Given this list of marker genes RNA5SP75 (RNA, 5S ribosomal pseudogene 75), RNA5SP19, RNA5SP490, RNA5SP37, RNA5SP22, RNA5SP151, RNA5SP106, RNA5SP280, RNA5SP166, NDUFS7, RNA5SP319, RNA5SP515, PEX3, RNA5SP387, REEP2, RNA5SP368, RNA5SP452, RNA5SP41, MT-RNR1, RNA5SP152 (RNA, 5S ribosomal pseudogene 152), DHX58, RNA5SP53, RNA5SP206, PLEKHG2, RNA5SP195, RNA5SP308, RNA5SP481, RNA5SP218, RNA5SP362, GYS1, RASGRP3, LTBP4, RNA5SP124, FAM230G, MTCO3P12, RNA5SP304, RNA5SP252, RNA5SP221, SYNE1, RNA5SP431, RNA5SP332, RNA5SP55, RNA5SP505, RNA5SP194, RNA5SP448, RNA5SP215, RNA5SP84, RNA5SP495, RNA5SP299, RNA5SP202, RNA5SP180, MAST1, RNA5SP393, MTND5P11, RNA5SP494, RNA5SP95, ACADS, MT-TF (NCBI Gene Id 4558), RNA5SP370, RNA5SP176, RNA5SP131, RNA5SP134, RNA5SP259, RNA5SP392, RNA5SP255, RNA5SP318, RNA5SP172, RNA5SP443, RNA5SP306, RNA5SP223, EMC1, RNA5SP482, RNA5SP471, RNA5SP183, RNA5SP198, RNA5SP46 (RNA, 5S ribosomal pseudogene 46), here is a description of the gene set: from publication Yevshin I, Sharipov R, Kolmykov S, Kondrakhin Y, Kolpakov F (PMID 30445619) Human Gene Set: GTF3A_TARGET_GENES Genes containing one or more binding sites for (GTF3A) in their promoter regions (TSS -1000,+100 bp) as identified by GTRD version 20.06 ChIP-seq harmonization. species: Homo sapiens